The following is a description of a gene set: Genes down-regulated in 9.5 days post coitus (dpc) embryos with COMMD1 knockout compared to normal 9.5 dpc embryos. from publication van de Sluis B, Muller P, Duran K, Chen A, Groot AJ, Klomp LW, Liu PP, Wijmenga C (PMID 17371845) Mouse Gene Set: VANDESLUIS_COMMD1_TARGETS_GROUP_3_DN species: Mus musculus COMMD1 (previously known as MURR1) belongs to a novel family of proteins termed the copper metabolism gene MURR1 domain (COMMD) family. The 10 COMMD family members are well conserved between vertebrates, but the functions of most of the COMMD proteins are unknown. We recently established that COMMD1 is associated with the hepatic copper overload disorder copper toxicosis in Bedlington terriers. Recent in vitro studies indicate that COMMD1 has multiple functions, including sodium transport and NF-kappaB signaling. To elucidate the function of Commd1 in vivo, we generated homozygous Commd1 null (Commd1(-/-)) mice. Commd1(-/-) embryos died in utero between 9.5 and 10.5 days postcoitum (dpc), their development was generally retarded, and placenta vascularization was absent. Microarray analysis identified transcriptional upregulation of hypoxia-inducible factor 1 (HIF-1) target genes in 9.5-dpc Commd1(-/-) embryos compared to normal embryos, a feature that was associated with increased Hif-1alpha stability. Consistent with these observations, COMMD1 physically associates with HIF-1alpha and inhibits HIF-1alpha stability and HIF-1 transactivation in vitro. Thus, this study identifies COMMD1 as a novel regulator of HIF-1 activity and shows that Commd1 deficiency in mice leads to embryonic lethality associated with dysregulated placenta vascularization., and this is the list of marker genes: Rgs2, Scg3, 6330403K07Rik (NCBI Gene Id 70751), Uchl1, Dmrt2, Trim9, Tcf15, En2, Hoxd12, Nnat, Spsb4, Tram1l1, Mfap4, Olig3, Crabp1, Tubb2a, Tmsb4x (thymosin, beta 4, X chromosome), Nr2f1, Mfap2, Dll3, Pcp4, Clec1b, Serf1, Vtn, Hddc3, Msln, Crabp2, Wfdc1, Cp, Nrarp, Fez1 (fasciculation and elongation protein zeta 1), Meox2, Tubb3, Nrep, Tgfbi, Vcam1, Yju2, Igdcc3